The following is a description of a gene set: species: Homo sapiens The transcription factor Foxp3 is usually considered the master regulator for the CD4+CD25+ Human Gene Set: GSE7460_WT_VS_FOXP3_HET_ACT_TCONV_UP Genes up-regulated in comparison of ActCD4 versus WTActCD4 (see Fig. 1 in the paper for details). from publication Hill JA, Feuerer M, Tash K, Haxhinasto S, Perez J, Melamed R, Mathis D, Benoist C (PMID 18024188), and this is the list of marker genes: TBC1D32, ZFAND2B, RABGAP1L, ATP2C2, CACNB1, ACAA2, GRPR, RPS6KA2, KANSL1, REN, MED1 (mediator complex subunit 1), BTLA, ESR1, PDE5A, ERBB3, S100A6 (S100 calcium binding protein A6), SRCAP, LEF1, POLL, TRAT1, PLOD1, SLC5A12, STK11IP, C12orf57, RFLNB, P2RX4, MOB3B, HAVCR1, ABHD8, USF2, ANKRD16, SMAD4, PGM2L1, ACAP1, GNAL, PEA15 (NCBI Gene Id 8682), AEBP1, HMBOX1, PLEC, ECE1, CCDC88C, ADGRL1, TMC8, FRY, EPHX1, ICAM2, ADAMTSL3, SLC30A4, FOS, NLRP10, KIZ, IQCF5, TSPAN17, TWF2, ALDH6A1, BTD, ARHGAP29, RHOG, DGKZ, NEIL1, SPOPL, MYSM1 (NCBI Gene Id 114803), WIPI2, DGLUCY, SPEF1, CLN3, ELF2, CREG1, EML3, FAM81A, RBM33, SFT2D1, METTL8, SQOR, SLC22A4, IL18R1, OAZ2, ERCC4, BRK1, RAMP1, SLC12A7, TSPO, HSBP1, FSCN3, USP6NL, DHX34, CTBP1, CYP19A1, SSH2, SPOCK2, SYTL1, ATPAF1, SNN, GRID2, AFF1, MKNK1, FHIP2A, GPR146, STAMBPL1, IFT80, PLEKHG2, SLC30A7 (NCBI Gene Id 148867), E4F1, STRC, BCL2L11, CD151, ACSS2, APPL2, DUSP11, GCH1, ZBTB20, GADL1, KIAA0930, EMP1, AGAP2, ARIH2, TANC1, SLC39A3, ZER1, ANKRD50, ANTKMT (adenine nucleotide translocase lysine methyltransferase), CHST6, ADAM2, TPRA1, TOX, CAMK2B, FOXD2, ZNF212, CYTH2, CEP164, QPRT, CYP39A1, NR1D2, PHKG2, GRAMD4, MBOAT4, DUSP7 (dual specificity phosphatase 7), VPS39 (NCBI Gene Id 23339), SENP7, PDLIM4, CCR7, ARHGAP15, FGF13, KDM7A, CDON, SEC16A, SLC2A9, DAPL1, PARD6G, PTTG1IP, CAMTA1, TCF20, CACNA2D2, SYNE2, HPCAL1, SPRN, SRPK2, PRXL2C, KCTD21, CTNND2, ELOVL7, SLC17A9, APOBEC1, RFX3, GDAP1, ARL4C, EEF2, LRCH1, SFT2D2, ATP2B1, AP5S1, SHE, ITPRIP, ADPGK, PROX2, SFSWAP, PIAS1, CTXN1, SHISA4, NRP1, URI1, RYR2, NECTIN2, WDSUB1, MID1IP1, GOLM1, LMOD3, IRAG1, ETHE1, SPRY1, KDM5A, NAAA, BPHL, PPM1L, EMP3, PXMP4, SLPI (secretory leukocyte peptidase inhibitor), PRKAB1, NUDT14